The following is a description of a gene set: from publication Feuerer M, Hill JA, Kretschmer K, von Boehmer H, Mathis D, Benoist C (PMID 20231436) species: Homo sapiens Genes up-regulated in comparison of TregCD103+Klrg1- versus TregCD103+Klrg1+ (see Table 1S in the paper for details). Human Gene Set: GSE20366_CD103_POS_VS_CD103_KLRG1_DP_TREG_UP Regulatory T (Treg) cells that express the FoxP3 transcription factor are essential for lymphoid homeostasis and immune tolerance to self. Other non-immunological functions of Treg cells, such as controlling metabolic function in adipose tissue, are also emerging. Treg cells originate primarily in the thymus, but can also be elicited from conventional T cells by in vivo exposure to low-dose antigen or homeostatic expansion, or by activation in the presence of TGFβ in vitro. Treg cells are characterized by a distinct transcriptional signature controlled in part, but not solely, by FoxP3. For a better perspective on transcriptional control in Treg cells, we compared gene expression profiles of a broad panel of Treg cells from various origins or anatomical locations. Treg cells generated by different means form different sub-phenotypes identifiable by particular combinations of transcripts, none of which fully encompass the entire Treg signature. Molecules involved in Treg effector function, chemokine receptors, and the transcription factors that control them are differentially represented in these subphenotypes. Treg cells from the gut proved dissimilar to cells elicited by exposure to TGFβ, but instead they resembled a CD103+Klrg1+ subphenotype preferentially generated in response to lymphopenia., and this is the list of marker genes: SH3BP5L, GLOD5, CYP4B1, KIF3A, MAP4K3, USP34, ADAMTS6, NSUN5, SMC4, SLC2A13, ZSCAN25, COQ2, DSP, PUS3, RCN1, TRIP10, ITGA6, CD96, NFKBIL1, BST1, POU1F1, HIPK2, TRIO, NUPR1, GPR45, RASSF8, OTUD5, GSTK1, SLC4A10, MBNL3, DKK4, CEP57L1, SLC22A5, CDHR4, PRKAG2, HEG1, CHTOP, RABGAP1, DPP10, INPP4B, NEMP1, MYC, PLA2G4F, SYT16, PELP1, RGS17, SLC26A2, PDZRN3, VASN, XPOT, SAMD7, CDC42EP1, ACER2, FAM91A1, F8, JMJD7-PLA2G4B, B4GALT4, OTX1, RPP14, PIAS2, FRYL (NCBI Gene Id 728298), DEFB106B, EMC1, SGPP1, EDEM1, ZNF827, MS4A6A, EGR2, DNAAF10, ADSS2, FBF1, BCAT2, PLXNC1, MMP11, ABTB2, TASP1, RABGAP1L, HIF1AN, WT1, KCNH2, MDN1, SGPP2, KCTD5, AIRN, PIP5K1B, PDE4DIP, LRATD1, DDC, ICE2, AFF3 (ALF transcription elongation factor 3), PPP1R14D, PCNX1, NGLY1, INAFM1, FBXW10, ASAP1, PRMT3, CRIM1, CEP95, PLEKHS1, METTL18, LTA, ATP4A, MAPK9, SLC6A18, HSDL2 (hydroxysteroid dehydrogenase like 2), ARC, THRB, SCG5, POU4F2, PPP4R2, SYNPO, TCTE1, WNT8A, PNPLA5, PUS7, TRPM7, TBXA2R, ALDH1B1, SNRK, HTATSF1, PIP4K2A, ITGB1, FUBP1, MGAT3, HDAC2, TSPAN3 (tetraspanin 3), CTSW, MAP10, PDLIM1, TM7SF2, MBP, TMEM38A, PNPLA3, SELL, SPEM1, GATA1, PRPF40B, DPP4, DHCR24, USP18, ARHGEF10, STX1A, DGKE, EEIG1, PRKCI, CILK1, CCDC62, HYAL2, FBXL12, BDH1, SPSB1, DIP2C, PCDHB15, MTAP, CPA1, PATJ, EXOC6, WDR3, RAB3IP, HIBADH, CDYL2, DUOX1 (NCBI Gene Id 53905), ZNF786, INTS6L, MCF2L, SLC16A1, PARP3, FUT10, RRP9, TIAM1, KLHL6, ZC3H12D, TUBB2A, P3H4, ABHD17C, DRC1, TGM2, PGPEP1L, MRC2, NFIX, LCN8, PGBD1, PHYHIP, ZC3H6, AKAP5, L2HGDH, AMPD3, BCAS1, CPEB3, METAP1, SPRY1, GUCY1B1, STK39, XDH, HSDL1, IKZF4 (NCBI Gene Id 64375), DHX33 (NCBI Gene Id 56919), KIF12, NGF